The following is a description of a gene set: Nitric oxide (NO) produced by macrophages (MØs) is toxic to both host tissues and invading pathogens and its regulation is therefore essential to suppress host cytotoxicity. MØ arginase 1 (Arg1) inhibits NO production by competing with NO synthases for arginine, the common substrate of NO synthases and arginases. Two signal transduction pathways control Arg1 expression in MØs. First, a MyD88-dependent pathway induces Arg1 in intracellular infections, while a second Stat6-dependent pathway is required for Arg1 expression in alternativelyactivated MØs. We found that mycobacteria-infected MØs produce soluble factors that induce Arg1 in an autocrine-paracrine manner via Stat3. We identify these factors as IL-6, IL-10 and GCSF. We further establish that Arg1 expression is controlled by the MyD88-dependent production of IL-6, IL-10 and G-CSF rather than cell intrinsic MyD88 signaling to Arg1. Our data reveal the MyD88-dependent pathway of Arg1induction following BCG infection requires Stat3 activation and may result in the development of an immunosuppressive niche in granulomas due to the induced Arg1 production in surrounding uninfected MØs from publication Qualls JE, Neale G, Smith AM, Koo MS, DeFreitas AA, Zhang H, Kaplan G, Watowich SS, Murray PJ (PMID 20716764) Human Gene Set: GSE22935_WT_VS_MYD88_KO_MACROPHAGE_48H_MBOVIS_BCG_STIM_UP Genes up-regulated in macrophages 48h after M. bovis BCG infection: wildtype versus MYD88 knockout. species: Homo sapiens, and this is the list of marker genes: TTC7B, CCSER2, IDH3B, PALLD, LGI1, HIF1AN, FLNC, HOXA7, CREBL2, NAXE, SMTNL1, NUDT9, NDP, CYS1, ANO3, CYP3A7, PSMG2 (proteasome assembly chaperone 2), DFFA, ANKRD2, PRMT7, ACACB, FRYL, AGR2, CHRDL1 (chordin like 1), GOT1, ACSL6, SEMA6D, NR4A1, SPTB (NCBI Gene Id 6710), TMIGD1, CUL5, ABCG2, CLDN5, TMEM60, EIF2B4, NMRK2, TARS3, WWP1, KLHL30, PLA2G12A, AOX1, TRIB2, ANKH, TSPAN7, NUDT6, COX6A2, NDUFA7, NQO1, NDUFB5, TMEM201, NOS1, GPN1, NRIP1, TPM2, MAPK12, ZRANB2, ETFB, BCKDK (branched chain keto acid dehydrogenase kinase), MSRA, RNF167, YPEL2, CCDC57, RASGRF2, CTNNAL1, COQ5, TNFRSF11B, PACSIN3, ATP6V0E2, FXYD1, PADI2, CHIC1, ITGA7, NFIA, ANKRD10, GNA11 (NCBI Gene Id 93626), NOL3, BOD1, TLN2, MTARC1, MLXIPL, KCNG1, RORC, NPR2, BSDC1, NEDD4L, FAM185A, RAPGEF4, EEF1A2, TTC9, IDH3A, SULT1A1, RABGGTB, MFN2, WFDC1, NPPC, DYRK1A, FBXO3, ITGB4, ATP5MC3, JPH2, HRC, KCNE5, NDUFAF5, USP2, KCNA7, RWDD4 (NCBI Gene Id 201965), ZDBF2, AKAP12, ARPP19, HDHD2, SDHA, COG6, PCNT (pericentrin), TF, FAM120AOS, HSPB7, UTRN, CDH9, HHATL, PRKAG3, KLHL23, PHYH, MELTF, TTL, NT5DC3, FITM2, ARHGAP19, DNAJC21, IGFBP5, SMARCD3, PGM5, ZFP91, ANK1, ADIPOR1, LAMB2, UBE3B, PNPLA2, UCMA, SCIN, TEFM, PPM1L, TCEAL7, CORO6, CLCC1, DAB2IP, PSMC4, AKTIP, ACSL1 (NCBI Gene Id 91249), EXTL2, ART1, ASB4, NDUFS3, LMTK2, COBL, PDSS2, CHST15, ENDOG, PDCD7, KRT12, SIX1, ALDH1A3, TMEM216 (transmembrane protein 216), EZH1, MAP4, DACT1, ZMYM4, SLC25A20, DNAJC2, GPD2, TMEM100, WFS1, CMKLR2, BVES, MKNK2, GID4, NDUFA10, VEZT, BOC, HERC1, SGCD, AATK, KYAT3, TCAIM, CDKAL1, CNTNAP4, DHX29, ATP5F1C, ST3GAL6, ZCCHC17, ZNHIT3 (zinc finger HIT-type containing 3), HSPB2, AK5, MYOM2, POLDIP2, ASB2, C6orf89, LAMA2, CSRNP2, ZFHX4